Given this list of marker genes LEP, SIRT1, MMP2, AFP, MMP19, FOXO3, PGR, ADAMTS1, NOS3, NRIP1, here is a description of the gene set: studied in species Homo sapiens The process leading to the rupture of the follicle, releasing the centrally located oocyte into the oviduct. An example of this is found in Mus musculus. Human Gene Set: GOBP_OVULATION_FROM_OVARIAN_FOLLICLE